Given this list of marker genes Ep300, Mtor, Nol3, Myog, Foxo3, here is a description of the gene set: Any process that modulates the frequency, rate or extent of muscle atrophy. species: Mus musculus Mouse Gene Set: GOBP_REGULATION_OF_MUSCLE_ATROPHY